The following is a description of a gene set: Human Gene Set: GOBP_REGULATION_OF_T_HELPER_17_CELL_LINEAGE_COMMITMENT Any process that modulates the frequency, rate or extent of T-helper 17 cell lineage commitment. species: Homo sapiens, and this is the list of marker genes: CD69, IL12RB1, BRD4, JAK3, LOXL3 (lysyl oxidase like 3), IL12B, BRD2, IL23R, IL23A, EP300, OPA1, TNFSF18, LGALS1, TBX21, STAT5A